The following is a description of a gene set: part of: Metabolism of nucleotides Reactome Pathway: Nucleotide catabolism species: Homo sapiens The purine bases guanine and hypoxanthine (derived from adenine by events in the purine salvage pathways) are converted to xanthine and then to uric acid, which is excreted from the body. The end-point of this pathway in humans and hominoid primates is unusual. Most other mammals metabolize uric acid further to yield more soluble end products, and much speculation has centered on possible roles for high uric acid levels in normal human physiology.<p>In parallel sequences of three reactions each, the pyrimidines thymine and uracil are converted to beta-aminoisobutyrate and beta-alanine respectively. Both of these molecules are excreted in human urine and appear to be normal end products of pyrimidine catabolism. Mitochondrial AGXT2, however, can also catalyze the transamination of both molecules with pyruvate, yielding 2-oxoacids that can be metabolized further by reactions of branched-chain amino acid and short-chain fatty acid catabolism.<p>Hydrolysis of phosphate bonds in nucleotides catalyzed by members of the NUDT and NTPD families of enzymes have been grouped here as well, although the physiological roles of these groups of catabolic reactions are diverse., and this is the list of marker genes: NUDT15, ENTPD5, NUDT16, TYMP, NUDT9, UPB1, UPP2 (uridine phosphorylase 2), ADPRM, AGXT2, ENTPD1, NT5E, DNPH1, ITPA, NT5C, ENTPD6, ENTPD4, ENTPD3, ENTPD7, NT5C3A, GDA, SAMHD1, NUDT5, DPYD, ENTPD2, NT5C1A, ENTPD8 (NCBI Gene Id 377841), XDH, PNP, DPYS, NUDT1, NUDT18, NT5C2, NT5C1B, NT5M, UPP1